Given this list of marker genes SUFU, FGFR1, GLMN, TGIF1, SHH, SIX3, FGF8, GAS1, PTCH1, DISP1, CRIPTO, DLL1, CDON, ZIC2, NODAL, GLI2, FOXH1, here is a description of the gene set: Abnormality of the nasal cavity (the cavity includes and starts at the nares and reaches all the way through to the and includes the choanae, the posterior nasal apertures). species: Homo sapiens Abnormal nasal cavity morphology Human Gene Set: HP_ABNORMAL_NASAL_CAVITY_MORPHOLOGY